Given this list of marker genes RAP1B, PBX1, KANSL1, WBP4, TAF4, RNU4-2, FGF3, BCOR, HMGB3 (high mobility group box 3), KAT6A, KCTD1, RPL10, TTI2, SYNGAP1, NHS, CACNA1G, here is a description of the gene set: Human Gene Set: HP_ANTEVERTED_EARS species: Homo sapiens Anteverted ears